The following is a description of a gene set: from publication Hervas-Stubbs S, Riezu-Boj JI, Gonzalez I, Mancheño U, Dubrot J, Azpilicueta A, Gabari I, Palazon A, Aranguren A, Ruiz J, Prieto J, Larrea E, Melero I (PMID 21108462) Genes down-regulated in CD8 T cells activated by anti-CD3 and anti-CD28 versus those stimulated by IFNA5. IFN alpha mediated gene expression pattern. The effect of IFN alpha on human CD8 T cells responding to antigen (signal 1) and costimulatory signals (signal 2) provided by beads coated with anti-CD3 and anti-CD28 mAbs. This analysis examined the effects of IFN alpha on human CD8 T cells responding to antigen (signal 1) and costimulatory signals (signal 2) provided by beads coated with anti-CD3 and anti-CD28 mAbs. Magnetically sorted untouched CD8+CD45R0- T cells from three different donors were unstimulated or stimulated with IFNa2b or with anti-CD3/CD28 Beads alone or along with IFNa2b or IFNa5 for 48 hours. Individual mRNA samples were analyzed using HG-U133A 2.0 array gene chips. species: Homo sapiens Human Gene Set: GSE17301_ACD3_ACD28_VS_ACD3_ACD28_AND_IFNA5_STIM_CD8_TCELL_DN, and this is the list of marker genes: SEPTIN11, MX1, TMEM8B, FLOT1, ERCC1, MAN2B1, RPP40, TCF4 (NCBI Gene Id 6925), HHEX, TRIM44, SCYL2, CCDC25, ZEB2, SPON2, IFI44L, CLIC3, SLC7A5, TFEC, ALOX5AP, GCLC, SLC25A15, SIK1, CTSB, TCL1A, SH2B3, CASP4, NPC1, NLE1 (notchless homolog 1), GUCY1A1, JAK2, GM2A, PTBP3, TNFSF13, CDH1, PTRH2, CTSH, DUSP7, PLXNB2, STAT4, CYBB, TRAF3IP2, HK2, HLA-DRB1, OPN3, CTSS, RABGAP1L, CREB3L2, IGLL1, TLR1, ATF5, TPP1, CSF2RB, DHCR7, JCHAIN, HERPUD1, SPIB, IQGAP2, TSPAN13, GNPDA1, RNF144A, STAP1, TPM2, ZFAND3, LILRA4, PUS7, BTN3A3 (NCBI Gene Id 135583), FCHSD2, BAZ2B, TST (thiosulfate sulfurtransferase), FOSB, RPS6KB1, PRKCD, MS4A4A, POLB, QTRT2, CD74, MSRB1, TGFBI, ARHGAP17, HLA-DMA, DPP4, IRF7 (interferon regulatory factor 7), PTGDS, QRSL1, CD302, CDYL, FXYD2, B4GALT1, IL3RA, CD55, GPD1L, TYROBP, MYO5A, IRF8, BHLHE40, PRKAA1, HIBCH, NDST3, KANK1, CDK6, RNASE6 (NCBI Gene Id 6039), PDIA5, RUBCNL, GPX1, FNDC3A, GPM6B, AHI1, CD93, GPR183, RAP1GAP2, PNMA8A, WDR41, DNASE1L3, FYCO1, MNDA, EMD, SSR3, LY6H, GLIPR1, ANXA4, PLAC8, CTSC, MICAL3, GRAMD1B, MEF2C, PPP1R15A, SERPINB1, LY96, TARBP1, RNF130, CCR2, GZMB, TMEM268, NPC2, PEA15, ACYP2, P2RY14, USP18, RGS19, CTNND1, POLR1E, THEMIS2, FEZ2, CD300A, MFAP4, OSBPL1A, CAPG, ADISSP, UGCG, TNFRSF17, UTRN, IL10RA (NCBI Gene Id 3587), SIDT1, DENND5A, SERPING1, MS4A6A, MILR1, MAPKAPK2, RPS6KA1, GLB1, ADAM9, LYN, TRIP6, APOOL, WIPF1, HLA-DPA1, LITAF, RGS2, TMEM184B (transmembrane protein 184B), HLA-DRA, BLNK, TAOK3, IQSEC1, IGF1R, HLA-DMB, ALDH2, NAMPT, GRN, DHRS7, HLA-DPB1, RUBCN, ST6GALNAC4, IFI27, LILRB4, DACT1, LAMP5, ENPP2 (ectonucleotide pyrophosphatase/phosphodiesterase 2), STX7, FCER1G, GTF3C2, RIOX2, SERPINF1, QDPR, RSU1, ZNF667, SH3BP4, FAM98A, KCTD12, SEL1L3, CHST12